Given this list of marker genes ANXA1, PLA2G2C, DRD2, PTGES, ABCC4, PROCA1, NTSR1, LEP, PLA2G2F, AVPR1B, SYK, PLA2G4A, PLA2G1B, CYP4A11, PLA2G5, PLA2G12B, EDN1, TNFRSF11A, NOS2, PNPLA8, PLA2G12A, IL1B, PLA2R1, MIF, ACSL4, NMUR2, CYP4F2, P2RX7, BDKRB2, NMB, PLA2G2D, DRD4, PLA2G2E, ACE (NCBI Gene Id 654142), PLA2G3, PLA2G2A, PTGS2, TNFSF11, PLA2G4F, DRD3, P2RX4, OXT, PLA2G10, OC90, here is a description of the gene set: The controlled release of icosanoids, any of a group of C20 polyunsaturated fatty acids from a cell or a tissue. Human Gene Set: GOBP_ICOSANOID_SECRETION studied in species Homo sapiens